Given this list of marker genes VDAC3, CYCS, ITPR1, SLC25A5 (NCBI Gene Id 292), VDAC2, SLC25A4, SLC25A6, VDAC1, PSEN1, MCU, SLC25A31 (NCBI Gene Id 83447), ITPR3 (NCBI Gene Id 3710), ITPR2, here is a description of the gene set: Human Gene Set: KEGG_MEDICUS_VARIANT_MUTATION_CAUSED_ABERRANT_PSEN1_TO_MGLUR5_CA2_APOPTOTIC_PATHWAY studied in species Homo sapiens Pathway Definition from KEGG: PSEN1* -> ITPR -> Ca2+ -- MCU -> Ca2+(mito) -- MPTP -> CYCS Mutation-caused aberrant PSEN1 to mGluR5-Ca2+ -apoptotic pathway. Pathway ID: N01008. Pathway type: Variant. Pathway class: nt06460 Alzheimer disease.